Given this list of marker genes ARMH4, CTSZ, SYNM, C11orf87, STIM1, MCM3, ZIC4, here is a description of the gene set: Human Gene Set: MIR10401_3P Genes predicted to be targets of miRBase v22 microRNA hsa-miR-10401-3p in miRDB v6.0 with MirTarget v4 prediction scores > 80 (high confidence targets). studied in species Homo sapiens from publication Chen Y, Wang X (PMID 31504780)